Given this list of marker genes Stat1, H2-D1, Kdr, Phyh, Sp100, Actr10, here is a description of the gene set: from publication Cui A, Huang T, Li S, Ma A, Pérez JL, Sander C, Keskin DB, Wu CJ, Fraenkel E, Hacohen N (PMID 38057668) Cytokines mediate cell-cell communication in the immune system and represent important therapeutic targets. A myriad of studies have highlighted their central role in immune function, yet we lack a global view of the cellular responses of each immune cell type to each cytokine. To address this gap, the authors created the Immune Dictionary, a compendium of single-cell transcriptomic profiles of more than 17 immune cell types in response to each of 86 cytokines (>1,400 cytokine-cell type combinations) in mouse lymph nodes in vivo. A cytokine-centric view of the dictionary revealed that most cytokines induce highly cell-type-specific responses. For example, the inflammatory cytokine interleukin-1β induces distinct gene programmes in almost every cell type. A cell-type-centric view of the dictionary identified more than 66 cytokine-driven cellular polarization states across immune cell types, including previously uncharacterized states such as an interleukin-18-induced polyfunctional natural killer cell state. Mouse Gene Set: CUI_PDC_IL12_RESPONSE_UP Genes positively differentially expressed in cell type: pDC (plasmacytoid dendritic cell) upon treatment with cytokine: IL-12 in mouse lymph nodes in vivo. studied in species Mus musculus